The following is a description of a gene set: Human Gene Set: GOBP_MELANOCYTE_DIFFERENTIATION studied in species Homo sapiens The process in which a relatively unspecialized cell acquires specialized features of a melanocyte., and this is the list of marker genes: MITF, BLOC1S6, SOX10, CITED1, MEF2C, ZEB2, ENPP1, LRMDA, GNA11, TYRP1, OCA2, OR51E2, ADAMTS20, KITLG, BCL2, EDN3, ADAMTS9, USP13, RAB27A, HPS4, EDNRB, MREG, KIT, GLI3